Given this list of marker genes GRK1, GNAT1, GRK4, NMT1, GUCY2F, NMT2, CAMKMT, GRK7, GUCY2D, AIPL1 (aryl hydrocarbon receptor interacting protein like 1), here is a description of the gene set: Human Gene Set: GOBP_REGULATION_OF_OPSIN_MEDIATED_SIGNALING_PATHWAY species: Homo sapiens Any process that modulates the frequency, rate or extent of opsin-mediated signaling.